Given this list of marker genes VDAC2, PKM, PTPRJ, ISCA1, CCT3, PBDC1, ADK, STAP2, NDUFA10, PPP2R1A, NDUFA4, CYSTM1, SEC11A, HAGHL, RPL27A, MAPKAPK5-AS1, MRPS15, SLC39A13 (solute carrier family 39 member 13), UBTD1 (NCBI Gene Id 80019), ITGB1BP1, RHOF, TIMM13, MRPL3, SCOC, DPP3, RGS10, CAPN2, COPS8, ATP5MC2, PGAM1, MITF, CHCHD3, ACAA1, NDUFA6, UQCC2, DLG1, JDP2, DHTKD1, MRPL50, LAT2, CADM1, FERMT3, IGFBP6, MLST8, NIPA1 (NCBI Gene Id 6686), ATP6V0E1 (NCBI Gene Id 8992), SDCCAG8, SND1, DDA1, MYO10, SEMA4D (semaphorin 4D), TM9SF2, SLC25A5, PTGES2, ACTN1, UQCRC2, SCARF1, NPC2, CXXC5, NME4, IGBP1, NENF, RMDN1, SLC25A3, CHCHD10, POLR2M, LINC02356, TSPAN15, EEIG1, SHFL, CUTA, PPP1R14B, MYO1C, TNFRSF11A (NCBI Gene Id 8792), UQCRB, C15orf61, ATP6V1E1, NSMCE1, HSPA9, ATP6AP1, EIF3K, DCAF13, ATP5ME, SPINT1, RPP25, GLRX3, ATP6V0D2, APOBEC3C, CA2, PDHA1, TRAP1, DNM3, MID1IP1, ATP6V1C1, ZNF467, MLF2, ORAI1, MRPL23, HIGD2A, TNKS1BP1, ADI1, ITGA2, CBLB, PTPMT1, ATP6V1D, LETMD1, TMEM147, ACER3, OCIAD2, NDUFC2, NDUFA1, GNL3, COX5B, MDH2, NFKBIL1, ORAI3, ATP6V1H, MT-ND5, PPA1, CTSK, GOLM1, A1BG, GNPTAB, PA2G4, IARS1, NDUFV1, ARPC1B, RETREG1, SLC37A2, CDK5, ETFB, UQCRH, EHD2, COX7A2, MRPL40, PALLD, HSD3B7, LSM12, ITGAV, SQOR, KIDINS220, ARL6IP5, NDUFB5, ESYT3, ATP5MG, GMPR2, SLC39A8, OSCAR, COX7C, SUPT3H, SUCLG2, MMP9, NDUFB2, MAST4, OXCT1, TNNI2, PRCP, SKAP2, MRPL4, ACAT1 (NCBI Gene Id 38), CERS2, ATG14, MCRIP2, SRD5A1, IDH2, TCIRG1, RAB13, EIF3G, ATOX1, NRIP3, NNT, N4BP2, COMMD3, PLBD1, BDH1, DUSP14, TKT, CST3, DNAJC4, COL27A1, RFTN2, ALKBH7, REPIN1, MRPL57, ECI1, AKAP6, SLC25A4, POLD2, MAP1LC3A, PIGT, EVI2A, IBTK, CYC1, SPR, MYO1D, ANPEP, NDUFS2, NFATC1, BBLN, LASP1, COQ8A, HYAL1 (NCBI Gene Id 3373), BOLA3, NUDT2, TTYH2, CKLF, PSMC6, TENT2, PTPN22, CISD3, TIMM9, PAGE2, SKIC3, MRPL37, F2R, DPP4, MRPL43, SH3BP2, SPHK1, NARS1, PHETA1, ATP5PB, SLC9B2, PHB2, URM1, SHTN1, TXN2, CLEC11A, VPS26B, IDH3G, CALM3, TMBIM4, COX7A2L, SIGLEC15, GLB1, TPGS2 (NCBI Gene Id 25941), APEX1, RAI14, HTRA3 (NCBI Gene Id 94031), AKR7A2, AGL (NCBI Gene Id 178), THOP1, ARHGAP10, MRPL36, TMEM255B, NDUFS8, EXT1, GRN, COX8A, MLX, GOT1, PARK7, OCSTAMP, CTNNBIP1, LTBP4, CARMIL1, FHL2, ETFA, NET1, ITGB3, ACSL4, SUCLG1, KIAA0040, NPM1, C19orf48P, GBE1, DLD, EOGT, XPR1, TMSB10, PARM1, C1QBP, FILIP1L, COX5A, SCFD1, MATK, PACC1, F5, SLC39A1, LYPLA1, MRPS33, CD33, NDUFS3, RICTOR, HSPB7, APP (amyloid beta precursor protein), PSMD3, FH, TOMM22 (translocase of outer mitochondrial membrane 22), H2AC6, MRPL41, WDFY1, SMIM19, BACE2, PTPN12, ACTN2, ARL2, FAIM, SLC4A2, FHL3, ZNF581 (NCBI Gene Id 96067), STRIP2, DGKZ, SLC30A9, CYTH4, PDLIM5, ZC3H8, PFDN4, AK5, DOCK5, FXYD6, CKB, CREG2, CENPX, BTBD10, EBP, RIOX2, HMG20B, ATP5F1D, H1-10, EXT2 (exostosin glycosyltransferase 2), PMPCB, MRPL15, MRPS30, TDRD3, PSTPIP1, ACP5, JAGN1 (NCBI Gene Id 84522), ECH1, UQCRFS1, NDUFV3, MYO1B, SLC25A13, SLC25A11, MRPS34, TWF2, DYRK4, SNX10, ANKH, ATP5MC3, SPNS2, RAB38, TPGS1, EIF3D, GTF2F2, STRADB, PRXL2A, BLVRA, ATP5F1C, PRPSAP2, LDHB, ADSS2, RAB34, GHITM, POLD4, ABHD2, MDFIC (NCBI Gene Id 29969), CARHSP1, ATP5MC1, UQCRC1, PFKP, TIAM1, CDC42EP5, LILRB4 (NCBI Gene Id 11006), FLII, MRPL44, IARS2, HPRT1, ACTG1, DGLUCY, FNBP1L, ARV1, XKR8, ATP6AP2, PLD1, MLXIP, CALCOCO1, PRDX3, TNNT1, ATP6V1G1, GUCD1, RUFY4, ESRRA, COL18A1, TMEM9B, CCND1, RPL22, COX4I1, ALDOA, ATP6V1B2, ATP5PO, LAT (NCBI Gene Id 27040), MVP, FBXW5, EPRS1, NDUFA9, ATP5F1A, MPST (mercaptopyruvate sulfurtransferase), ECHS1, NME3, TXNDC17, ATL3, VASH1, ANXA2, CACNA2D4, CCDC115, MPG, PDHB (NCBI Gene Id 5162), ATP6V0B, RNLS, MRPS2, MBOAT7, ATP6V1A, KGD4, MUC20-OT1, GRHPR, ACO2, TRPV2 (NCBI Gene Id 51393), HDDC2, PTTG1 (PTTG1 regulator of sister chromatid separation, securin), GPR137B, UBAC1, SLC16A7, NAA10, SMARCA4, CD276, HYAL2, MGMT, COX7B, SLC29A1, UQCR11, MT-ND4L, MOCS2, HSD17B8, CD84, TM4SF19, BABAM2, FRAT2, NDRG4, CALHM2, PICK1, ZDHHC4, DEF8, GBGT1, ATP5F1B, MRPL12, CD109, PPP1R7, CYB5R3, NDFIP2, SYCE1L, CSNK2A1, RILP, TK2, RGS19, GNS, PTRHD1, ATP2B4, OXR1, MAP4K4, ARFGEF3, FAM20C, MAP1A, PRADC1, SRC, ATP5MK, SPRING1, NDUFA7, CFL2, AIG1, here is a description of the gene set: The transformation of benign lesions to malignant tumours is a crucial aspect of understanding chondrosarcomas, which are malignant cartilage tumours that could develop from benign chondroid lesions. However, the process of malignant transformation for chondroid lesions remains poorly understood, and no reliable markers are available to aid clinical decision-making. To address this issue, we conducted a study analysing 11 primary cartilage tumours and controls using single-cell RNA sequencing. By creating a single-cell atlas, we were able to identify the role of endoplasmic reticulum (ER) stress in the malignant transformation of conventional central chondrosarcomas (CCCS). Our research revealed that lower levels of ER stress promote chondrosarcoma growth in a patient-derived xenograft mouse model, while intensive ER stress reduces primary chondrosarcoma cell viability. Furthermore, we discovered that the NF-?B pathway alleviates ER stress-induced apoptosis during chondrosarcoma progression. Our single-cell signatures and large public data support the use of key ER stress regulators, such as DNA Damage Inducible Transcript 3 (DDIT3; also known as CHOP), as malignant markers for overall patient survival. Ultimately, our study highlights the significant role that ER stress plays in the malignant transformation of cartilaginous tumours and provides a valuable resource for future diagnostic markers and therapeutic strategies. from publication Su Z, Ho JWK, Yau RCH, Lam YL, Shek TWH, Yeung MCF, Chen H, Oreffo ROC, Cheah KSE, Cheung KSC (PMID 38267611) species: Homo sapiens Human Gene Set: SU_HO_CONV_CENT_CHONDROSARCOMA_LEUKOCYTE_C4_OSTEOCLAST A monocyte lineage derived cell population responsible for bone absorption. It contained distinct markers (TNFRSF11A, NFATC1, ACP5, and SIGLEC15) and specific gene ontology terms (osteoclast differentiation, bone resorption, and bone remodelling). Monocyte lineage marker CD68 was universally expressed.